Given this list of marker genes MARF1, KDM2B, SNTB2, LIMA1, ABI1, LINC02100, GPR141, PPM1K-DT, ITGB7, STAT4-AS1, SLC6A12, SYNPR, APOL6, CDK14, IFNA2, ATXN7L3B, PNPLA8, RGS1, TMEM117, TMX4, DHTKD1, APOBEC3B, METTL27, KAT7, BTN2A2 (butyrophilin subfamily 2 member A2), MOB1A, ZNF19, LINC00652, TRAJ30, MIEF1, ZNF175, NOTCH4, DCTD, CAMK2D, ISG20, AFG2B, DUSP16, NDE1, FAM98C, CFAP418, FAM117A, LINC02404, GJC1, STAP1, DCAF8, CCDC198, FHIT, MYO3B, CALCOCO2, ACTBP9 (NCBI Gene Id 69), MEF2C, TXLNB, REPS1, NKAP, LCDR, GRIP2, RN7SL346P (RNA, 7SL, cytoplasmic 346, pseudogene), COX7CP3, EVI2A, SLC25A26, TBL2, LUC7L3, ZNF785 (NCBI Gene Id 146540), ST3GAL1, RN7SKP9, EFL1P2, RABGAP1L-AS1 (RABGAP1L antisense RNA 1), INPP1, LINC02090, TNFSF10, TAT-AS1, RAB18, IL9RP3, RNU6-1096P, GIHCG, CTSS, FGF18, VMP1, TMEM244, DMAC2L, CCAR1, CEP128, CD80, SLFN11, TM7SF3, TMTC3, ARL6IP5, ZNF484 (zinc finger protein 484), SCYL2P1, GAB1, TNIK, SLC25A29 (solute carrier family 25 member 29), ZNF211, LINC01871 (NCBI Gene Id 105373483), SORT1 (NCBI Gene Id 6272), SERPINB9P1, TTN-AS1, RNU6-797P, C2CD2 (C2 calcium dependent domain containing 2), PPM1K, NSUN3, TACC1, CCDC102B, DHFR2, BCL9L, PPP2R5C, ERICH3, KPNA1 (karyopherin subunit alpha 1), CYTIP, TMBIM4, IGHV3OR16-16, CDC14A, ZNF222, EIF4G3, FRRS1, BACH1, HLA-DRB1, PRLR, KATNBL1, EPB41L1 (erythrocyte membrane protein band 4.1 like 1), ENPP7P8, NEDD4L, ENSG00000254951, ARHGAP21, KIAA0319, KCTD21-AS1, LINC01426, CHML, KRI1, LINC00293, LINC02977, NMT2, EPDR1, BBX, ITPRID2, C1QTNF2, TADA1, LINC01934, TARBP1, SEPTIN2, NASP, NEDD9, LINC02564, LINC01825, COPS5, TRIM22, ALG8, TRAK1, HMGB3P1, LNCATV, ARF4, CDV3, BUB1 (NCBI Gene Id 699, BUB1 mitotic checkpoint serine/threonine kinase), WEE1, PRDM1, ADAM8, CD74, MIR4437, HINT3 (histidine triad nucleotide binding protein 3), SAMD14, TPP1, ENSG00000238387 (novel transcript), CD69, ANP32B (acidic nuclear phosphoprotein 32 family member B), ZNF776, FOXP1, GMFB, LINC02945, CASP8, LINC02684, ZNF222-DT, IGF1, BSG, ZNF500, CCL4, NDRG2 (NDRG family member 2), ACTR2, POLR2E, RN7SKP123, SLC25A45, TMCC1, EPRS1 (NCBI Gene Id 2058), HSD17B11, BMAL2, YARS1, LINC01892, SYNJ1, CLEC2D, IDO2, FOXN3, NPSR1-AS1, WDR86-AS1, MTSS1 (NCBI Gene Id 9788), SLC25A46, IFT46, LINC00607, TRIM34, PLEK, SLC11A1, TANK, RHEB, RSBN1, SEL1L2, RASGRP3, KLHL2, LINC02898, IRF2BP2, GMDS-DT (NCBI Gene Id 100508120), GALK1, MIR5194, SERPINA1, BLVRA, ACTR6, CLUHP5 (NCBI Gene Id 100418745), TLK2, MRTFA (myocardin related transcription factor A), EVI2B, RRAGC, LAX1, IGLV7-46, ZNF541, H2BC10, EYA3, PTK2B, REV3L, LINC02642, DIXDC1, SNRPD1 (small nuclear ribonucleoprotein D1 polypeptide), TASL, GATM, HROB, CLIP1, RNU6-452P, UMODL1, JMJD1C, PHLDB2, IFNG, PCDH12, BCDIN3D, IFNG-AS1, C12orf42, MT-RNR2, DGUOK, TRAJ35, WDR54, PEX10, TMCO4, ELF1, TNRC6B, RNU1-78P (RNA, U1 small nuclear 78, pseudogene), ZNF236, MILR1, MIR3680-1, SYCP2, PIK3R1, RSPH14, OTUD5, ABHD17C, CEP290, BANK1, IGHV3-16, NFAT5, PPP2R5B, CD22, MTHFD2, ARL14EP, HLA-A, PRKACB, BUB1B, TMX3, UQCRB, CDK7 (NCBI Gene Id 116024), NCKAP1L, ATG2A (autophagy related 2A), SCP2, MTHFD1L, CSPP1, FMO4, FNDC3B, ZNF366, UST, GORASP1, H2AC10P (NCBI Gene Id 8333), RGS3, CD300LD, ASIC1, C1D, HLA-DPB1, SQOR, LINC01091, SMG6, NFYC, AOAH, SNRPEP5, SPG11, MT-TV, GNG5, PLCH2, here is a description of the gene set: Genes containing one or more binding sites for (TERF1) in their promoter regions (TSS -1000,+100 bp) as identified by GTRD version 20.06 ChIP-seq harmonization. from publication Yevshin I, Sharipov R, Kolmykov S, Kondrakhin Y, Kolpakov F (PMID 30445619) Human Gene Set: TERF1_TARGET_GENES studied in species Homo sapiens